The following is a description of a gene set: studied in species Mus musculus Combining with neuropeptide Y to initiate a change in cell activity. Mouse Gene Set: GOMF_NEUROPEPTIDE_Y_RECEPTOR_ACTIVITY, and this is the list of marker genes: Npy5r, Prokr1, Npy1r (neuropeptide Y receptor Y1), Prokr2, Qrfpr, Gpr83, Npy4r, Prlhr, Npy6r, Npy2r